The following is a description of a gene set: species: Homo sapiens Human Gene Set: WP_OLIGODENDROCYTE_SPECIFICATION_AND_DIFFERENTIATION_LEADING_TO_MYELIN_COMPONENTS_FOR_CNS Oligodendrocyte specification and differentiation, leading to myelin components for CNS, and this is the list of marker genes: OLIG2, TNF, SOX8, NKX2-2, ASCL1, OMG, MAG, FGF2, SOX9, PLP1, MOG, SHH, MBP, IL1B, BMP2, GLI2, BMP4, SOX5, CNP, PDGFB, OLIG1, IGF1, CXCL2, LIF, SOX10, MYT1, CNTF, NKX2-6, CXCL1, SOX6